The following is a description of a gene set: electronically inferred by orthology from the curated human pathway Reactome Pathway: Effects of PIP2 hydrolysis This event has been computationally inferred from an event that has been demonstrated in another species.<p>The inference is based on the homology mapping from PANTHER. Briefly, reactions for which all involved PhysicalEntities (in input, output and catalyst) have a mapped orthologue/paralogue (for complexes at least 75% of components must have a mapping) are inferred to the other species. species: Mus musculus part of: G alpha (q) signalling events; Platelet activation, signaling and aggregation, and this is the list of marker genes: Trpc6, Dgkh, Dgkb, Trpc7, Dgka, Dagla, Dgki, Prkch, Daglb